The following is a description of a gene set: Human Gene Set: GOCC_POSTSYNAPTIC_ACTIN_CYTOSKELETON The actin cytoskeleton that is part of a postsynapse. studied in species Homo sapiens, and this is the list of marker genes: ITSN1, ITPKA, MYO9B, CTTNBP2, CTTN, ACTN4, ACTN2, KPTN, ACTB, MYH10 (myosin heavy chain 10)